The following is a description of a gene set: Human Gene Set: REACTOME_PHASE_II_CONJUGATION_OF_COMPOUNDS species: Homo sapiens Phase II - Conjugation of compounds, and this is the list of marker genes: ESD, TPMT, TPST2 (NCBI Gene Id 8459), TPST1, N6AMT1, ACSM5, SULT2B1, GSTM1, UGT2B15, SULT1A2 (sulfotransferase family 1A member 2), GLYATL1, UGT1A6, ACSM4, GSTT2B, GSTA1, AHCY, MTR, MGST1, ABHD10, SULT1E1, SULT2A1, UGT1A5, GSTP1, UGDH, SULT1C4, GGT5, PODXL2, UGP2, SULT1B1 (NCBI Gene Id 27284), AKR1A1, UGT2B10, SULT1A4, COMT, ACSM2A, GSTO2, UGT1A1, MGST3, GSTA5, GSTM3, SULT4A1, UGT2A3, UGT2A2, CNDP2, BPNT1, UGT1A7, SULT1A3, UGT2A1, MAT1A, SLC35B3, SULT1C2, TRMT112, ACSM1, MAT2B, SULT1A1, AS3MT, UGT2B11, UGT3A2, SLC35B2, CHAC1, UGT3A1, UGT1A8, PAPSS2, GSTM2 (NCBI Gene Id 82152), NNMT, BPNT2, GSTA2, GSTT1, GSTM5, NAT1, GSTO1, ACSM2B, PAPSS1, UGT2B4, GGT7, MAT2A, GGT1, CHAC2, GGT6, SLC26A2, UXS1, SLC26A1, NAT2, HPGDS, UGT2B17, GSTK1, GLYAT, GGCT, MTRR, CYP1A2, GSTA3, UGT2B28, MGST2, GLYATL2, GSS, GSTM4, OPLAH, UGT1A10 (UDP glucuronosyltransferase family 1 member A10), SLC35D1, UGT2B7, GSTZ1, SLC35D2, UGT1A4, SULT6B1, GSTA4 (glutathione S-transferase alpha 4), GSTT2, GCLM, GLYATL3, UGT1A3, GCLC, ABHD14B, UGT1A9 (UDP glucuronosyltransferase family 1 member A9)